Given this list of marker genes DYNC1H1, USH2A, ADGRV1, FZD9, FGD4, MYO1D, AMN1, EPHA4, CLCA1, PPP1R9A, ACTN2, OTOP1, PIEZO2, WWOX, MYO1E, CUBN, UNC5C, GRXCR1, MUC20, IQGAP2, NOS1AP, PALM, UBE2K, ADCY6, VASP, SLC6A6, DAG1, STX4, PIEZO1, BAIAP2, FCRL3, CIB2, SPN, MYO1B, ATP8B1, AP2A1, FGF13, S100P, MYO3A, VCAM1, ENPP7, MAP2 (NCBI Gene Id 4133), TBC1D10A, KPTN, TRIOBP, BBS2, DMD, VIL1, TMC1, TPRN, CDC42, STARD10, HLA-G, CLRN2, ERMN, ANTXR1, NGDN, WHRN, UBE2Q1, PDGFRA, SLC7A8, TBC1D10C, ATP6V1E1, FAT1, LRRK2, STRC, TWF2, ACTG2, MYO6, SLC7A11, ANKRD24, TUBB3, GPM6A, IZUMO1R, INPPL1, TGFB1, B4GALT1, ITGB1, ACTC1, PLS1, ARF6, ITGA3, MPP1, USH1C, TM4SF19, DCXR, TEK, FSCN2, TENM2, CTNNB1, SLC4A7, CFL1, CLIC5, FMN2, FOXA1, CALB2 (calbindin 2), CALML4, AOC3 (NCBI Gene Id 8639), ESPNL, LHFPL5, PDZK1, HYAL2, UTRN, EPHB1, WASH3P, SHTN1, ANKS4B, SYNE2, CALB1, CDHR2, CD302, CIB1, OSBPL3 (oxysterol binding protein like 3), SLC38A4, TSPEAR, TIAM2, GAP43, SPEF1, MYO1G, CA9, MSN, ELMOD3, CDH23, PODXL, CLIC4 (NCBI Gene Id 25932), TTYH1, ACTA2, EPS8L2, ICAM2, LY6G6D, FSCN3 (fascin actin-bundling protein 3), ABI1, NLGN1, KITLG, SPATA13, STRCP1, CD44, ATP6V1B1, RHOC, FCHSD2, RAPH1, ABI3 (NCBI Gene Id 51225), PROM1, CXADR, MTTP, PPP1R9B, PLEKHG6 (pleckstrin homology and RhoGEF domain containing G6), APP, MYO5A, ESPN, ENAH, SLC27A4, FARP1, CRB1, NF2, CDK5, TMC2, MYO1F, MYO1H, ABI2, ITGAV, RIPOR2, MTM1, PDGFA, GRXCR2, LCP1, MORN4, EPS8, FSCN1, CEACAM16 (CEA cell adhesion molecule 16, tectorial membrane component), MYO1A, PKHD1L1, PDZD7, PAFAH1B1, CBLIF, DOCK4, PJVK, FABP2, AQP5, IFT20, DEF6, DYNC2I2, VEZT, CEACAM20, PTPRQ, CDC14A, EXOC4, ADGRA2, IGF2BP1, FZD3, HOMER2, DPEP1, ATP6V1B2, SLC7A5, SCIMP, TWF1, ABITRAM, MYO10, EZR, DNALI1, MYO7B, JAM3, CDHR5, AMN, ITGB3, ARL4C, PTPRH (protein tyrosine phosphatase receptor type H), CLRN1, RUFY3 (NCBI Gene Id 441022), FMR1, MYO15A, PDPN, MYO3B, CEACAM1, PCDH15, SLC10A2, LOXHD1, PROM2, NHERF1, TRPV4, MYO7A, MYO1C, ACTA1, RDX, ATP6V1A, ANGPT1, MINAR2, SLC26A2, SYTL1, RAPGEF3, ACP3, here is a description of the gene set: A cell projection supported by an assembly of actin filaments, and which lacks microtubules. Human Gene Set: GOCC_ACTIN_BASED_CELL_PROJECTION studied in species Homo sapiens